Given this list of marker genes RAPH1, TAB3, NKX2-2, RAB10, IRS1, SMIM14, BTBD10, FGD6, DSTYK, CBX2, TMEM121B, ACTR1A, EPB41, LGI1, LHX8, ERG, NT5E, CLDND1, SH3RF1, CYP24A1, STC1, PRLR (NCBI Gene Id 5618), ADAMTS9, MKRN3, ARF4, DOC2A, TMED2, CPEB4 (cytoplasmic polyadenylation element binding protein 4), ARL6IP6, GNAO1, GFPT2, GRM3, ZNRF1, BAHD1, SORCS3, SLC38A2, GSKIP, STAG2 (NCBI Gene Id 10735), GLDC, ADRB1, YTHDF3, LCLAT1, FBXO34, GRIA2, ZFYVE26, RFX6, DAG1, RAB38, PLCXD3, ATG5, CDK19, CAMK2N2, OTUD4, RASD1, MEX3B, ASCC3, ATP2A2, CUL2, BSN, SLC6A9, DOLPP1, HERC2, SEC23A, SNW1, RGL1, CNOT6, PRICKLE1, RUBCNL, PHACTR2, WBP1L, TENT2 (NCBI Gene Id 167153), PPP4R4, PER2, TENT5C, MECP2, REEP3, CHKA, KCNJ3, RGCC, UBE2F, STX2, PPP1R14C, ITGA6, SATB2, MNT, PPP3R1, VAT1, JADE2, UBE2D2 (NCBI Gene Id 7322), GARRE1, AP2A1, RAD23B, SCN8A, AMOTL2, SOCS3, SAP30, CELF3, NHLH2, ZNF644, TWF1, RNMT, NDEL1, XPO1, GTF2H1, EML4, NCOR2, ANKRA2, SEMA6A, TASP1, ERLIN1, PPTC7, MYH10, ENOX2, DNMT3A, ADAM9, ELMOD2, BNC1, EPC2, SEMA6B, CDC37L1, DEXI, NECAP1, CAPN5, HIC2, ATP2B1, NUFIP2, CBFB, SLC35D3, RAB11A, PPID, ZCCHC2, KCTD8, SERPINE1, DGKZ, CAPZA1, LARGE1, HLF (HLF transcription factor, PAR bZIP family member), PFN2, ST8SIA4, SPAST, DLL4, PHETA1, LARP4, ZBTB7A, ZBTB39, CCDC120, EBF3 (EBF transcription factor 3), KSR1, KRAS, UBN1, ANO4, PLPPR4, JOSD1, SEH1L, SBK1, ATXN1, ADRA2B, PRUNE2, FOXG1, SP4, FBXL17, BNC2, GJA1, DESI2, PSMD7, RARG, NAA25, YWHAZ, IL1A, WIPF1, ITGB3, CELSR3, MYBL2, SYPL1, PCDH10, SOX9, TRPS1, EFNA3, CCPG1, PIGA, ZNF608, TBC1D15, MIER2, NHSL3, WDR44, SSH2, ASB3, ADGRA2, KPNA3, ADAM19, DAGLA, TMEM47, SYNGR3, NEDD4, STK35, PAPOLB, YTHDC1, NEUROD1, PSEN2, SPEN, MAP6, JAG2, PAWR, KLHL24, PTP4A1, B4GALT6, HOXA11, DET1, SPTSSB, C16orf87, MAP3K12, CBLB, YPEL2 (NCBI Gene Id 388403), TMCC1, RBFOX1, TTBK1, MAT2A, ADO, UNC5C, RGS2, AFAP1L2, GALNT2, CEP41, SOBP, HDAC9, IKZF2, KLF10, RALGPS1, GNAI2, AVL9, EDEM3, KCTD5, FAM83F, FAM110B, IRF4, HSPA5, TAOK1, CPSF6, PCDH20, PON2, ZNF746, ZNF507, COPS7B, SCAMP1, USP44 (ubiquitin specific peptidase 44), RHEBL1, PAK5, SCYL3, CHD7, ACTC1, INSIG2, NCAM1, USP47 (ubiquitin specific peptidase 47), NAGPA, FRMPD1, NEUROD6, GALNT7, ARMH3, PCDH17, NR5A2, BCL9, STOX2, BRD1, ITSN1 (intersectin 1), FAP, TDG (thymine DNA glycosylase), VAPA, TLL2, AGO1, SCARA5, CAMKK2, CEP170B, STK39 (NCBI Gene Id 27347), ELOVL5, LYST, HECW2, ADGRL3, HLX, RAB15, CPEB2, ELL, LMBR1L, NAALADL2, YPEL5, CTNND2 (catenin delta 2), FCHO2, TNXB, SUPT3H, OMG, MBNL2, RAPGEF4, BNIP3L, RABL6, MAGI2, SRGAP3, PIP5K1B, TSPAN33, RNF122, CCNE2, ACVR1, FHIP2A, FRK, FAM131B, SIX4, ZCCHC24, FBXL20 (NCBI Gene Id 90110), SBF1, SNAI1, PHTF2, CSNK1A1 (casein kinase 1 alpha 1), PLAG1, ZBTB41 (zinc finger and BTB domain containing 41), SON, PSME3, UBE3C (NCBI Gene Id 9690), SLC35F1, CCNT2, KIAA0408, PIK3CD (phosphatidylinositol-4,5-bisphosphate 3-kinase catalytic subunit delta), SEMA3A, DCUN1D3, SOX12, IP6K3, PCGF5, ZNF280B, GZF1, ANAPC1P2, EAF1, PPARGC1B, CILK1, CACNB2, ANKRD17, KDM3A, CARS1, DOCK7, RUNX1, MARCHF6, LPGAT1, TULP4, RHOB, EIF5A2, FNDC3A, NRIP1, BAZ2B, FAM91A1, NUS1, SLC39A10, ZFX, ACAP2, PLAGL2, GLCE, MEIS2 (Meis homeobox 2), CHST2, CAMK2D, ABL1, DIP2B, CHST1, SCN3A, SSX2IP, MAP3K5, LRCH2, B3GNT5, PRRT2, NKAIN2, RASL12, KCNJ12, CAMTA1, IER2 (immediate early response 2), REV1, ARK2C, SLC9A8, NFAT5, GLCCI1, RARB, CCDC43, TTLL7, ZCCHC14 (zinc finger CCHC-type containing 14), ATOSA, DHX40 (NCBI Gene Id 79665), LIN28B, TIMP3, DMD, ZFC3H1, TBC1D10B, ZNF706, C9orf85, LIN28A, RAP2C, CSNK1G1, ESPN, BECN1, JAKMIP2, PGM1, LIFR, RAB8A, SEPTIN7, PRDM1, JDP2, NR4A2, GRHL2, GALNT1, ELL2, QKI, AFF4, PICALM, CPNE8, ZMYND8, CCNK, SNX33, TIA1, PNKD, CA10, POU4F2, SIRT1, BRD10, TMEM87A, SETD7, URM1, CNTD1, COL13A1, RAB4B, KCTD3, DNAJC13, GIGYF2, RASA1 (RAS p21 protein activator 1), TMEFF1, NRK, NFIB (NCBI Gene Id 4781), MAFG, EDNRA, MMD, SLC38A7, RAP1B, FAM210B, SLC36A1, NLGN1, CYRIA, CELF2, JADE3, ARID5B, PROSER1, PTPN13, TNRC6B, TMEM121, ARID3A, PNN, EXTL2, TNRC6A, MTCP1, RRAD, ZDHHC17, STRIP1, FAM43A, NHS, VAT1L, NRP2, DLG5, ARID4B, ADAMTS6, LRRC8D, EED, DDIT4, LRFN2, NEK4, E2F3, RNF220, CADPS, PCDH19, DPYSL2, GALNT3, PLXNA1, USP37, CALU, R3HDM1, MIER3, FAM13A, BTBD7, SETD3, STIM2, NEDD4L, MAN1A2, NADK, LPP, SLC25A14, MBNL3, MTDH, JPH4, DLGAP4 (DLG associated protein 4), RNF44, RUNX2 (RUNX family transcription factor 2), GOLGA4, RIMBP2, GRB10, PAPOLA, SMARCD2, ESRRG, TMOD2 (NCBI Gene Id 29767), KHNYN, DIO2, UBE2J1, CCDC117, SLC5A11, XPR1, MATR3, PIK3R2, BRWD1, AQP4-AS1, ZDHHC21, SLC7A10, SRSF7, ARHGEF6, BCOR, MFSD6, PTGFRN, PDCL, UBE2V2, SLC1A2 (NCBI Gene Id 6506), AHNAK, AP3S1, SGCB, FOXD1, KLHL20, PHF6, YBX3, EDC3, EDNRB, CIT, SH3PXD2A, SOX4, GRM5, PPP1R12A, FRMD6, LIN7C, KLF9, CHMP2B, CRKL, SOCS1, RAB32, NRP1, MAN1B1, KMT2A, TRPM7, MAML1, SWT1, VKORC1L1, GRHL1, ELAVL3, USP48, MARCHF4, ADAMTS3, SCN2A, ZFAND5, BCL2L11, FHOD3, FKBP3, DCX, PDE4D, KCTD7, P4HA2, ESCO1, ARID4A, RANBP10, TRAPPC14, GMEB2, SLC41A2 (solute carrier family 41 member 2), ANKHD1, UBE2I, MICAL1, FYCO1, ARL8B, WDR7, ATP2B2, NRXN3, CRACDL, KCNMB2, EPHB2, PTPN2, STAC, CCDC97 (NCBI Gene Id 90324), CFL2, here is a description of the gene set: species: Homo sapiens Human Gene Set: TGTTTAC_MIR30A5P_MIR30C_MIR30D_MIR30B_MIR30E5P Genes having at least one occurence of the motif TGTTTAC in their 3' untranslated region. The motif represents putative target (that is, seed match) of human mature miRNAs hsa-miR-30a-5p, hsa-miR-30c, hsa-miR-30d, hsa-miR-30b and hsa-miR-30e-5p (v7.1 miRBase).